The following is a description of a gene set: Human Gene Set: REACTOME_VXPX_CARGO_TARGETING_TO_CILIUM VxPx cargo-targeting to cilium species: Homo sapiens, and this is the list of marker genes: PKD1 (NCBI Gene Id 5310), EXOC6, EXOC3, EXOC4, EXOC5, EXOC1, RHO, EXOC8, RAB3IP, PKD2, ARF4, GBF1, CNGA2, EXOC2, RAB8A, EXOC7, RAB11A, CNGA4, CNGB1, RAB11FIP3, ASAP1